Given this list of marker genes F10, EPHX2, RNASE4, SERPINA10, PAH, GJB1, APOC3, SLC2A2, CRAT, MTSS1, ACSL5, CHI3L1, PKLR, RGN, CYP2J2 (cytochrome P450 family 2 subfamily J member 2), CYP27A1, PLG, SFTPC, AQP9, SULT2A1, ADH6 (alcohol dehydrogenase 6 (class V)), CYB5A, MST1, CDO1, CYP4F12, SERPINF2 (NCBI Gene Id 5345), HNF4A, IQGAP2, CRYL1, SLC22A7, LECT2, ADH1B, BPHL (NCBI Gene Id 83355), ITPR2, F5, C1orf115, GPHN, KHK, TBX3, C4BPB, COBLL1, SLC30A1, SERPINC1, here is a description of the gene set: Genes under-expressed in hepatocellular carcinoma (HCC) with poor survival from publication Villanueva A, Hoshida Y, Battiston C, Tovar V, Sia D, Alsinet C, Cornella H, Liberzon A, Kobayashi M, Kumada H, Thung SN, Bruix J, Newell P, April C, Fan JB, Roayaie S, Mazzaferro V, Schwartz ME, Llovet JM (PMID 21320499) Human Gene Set: KIM_LIVER_CANCER_POOR_SURVIVAL_DN In approximately 70% of patients with hepatocellular carcinoma (HCC) treated by resection or ablation, disease recurs within 5 years. Although gene expression signatures have been associated with outcome, there is no method to predict recurrence based on combined clinical, pathology, and genomic data (from tumor and cirrhotic tissue). We evaluated gene expression signatures associated with outcome in a large cohort of patients with early stage (Barcelona-Clinic Liver Cancer 0/A), single-nodule HCC and heterogeneity of signatures within tumor tissues. studied in species Homo sapiens